Given this list of marker genes RBBP6, RABIF, HMMR, UBE3D, SRRM1, GATD3, here is a description of the gene set: from publication Stoner GD, Dombkowski AA, Reen RK, Cukovic D, Salagrama S, Wang LS, Lechner JF (PMID 18676871) studied in species Rattus norvegicus Genes down-regulated in esophagus by the carcinogen NMBA and brought back to normal by a diet with PEITC or black raspberries. Our recent study identified 2,261 dysregulated genes in the esophagi of rats that received a 1-week exposure to the carcinogen N-nitrosomethylbenzylamine (NMBA). We further reported that 1,323 of these genes were positively modulated to near-normal levels of expression in NMBA-treated animals that consumed dietary phenylethyl isothiocyanate (PEITC), a constituent of cruciferous vegetables. Herein, we report our results with companion animals that were fed a diet containing 5% freeze-dried black raspberries (BRB) instead of PEITC. We found that 462 of the 2,261 NMBA-dysregulated genes in rat esophagus were restored to near-normal levels of expression by BRB. Further, we have identified 53 NMBA-dysregulated genes that are positively modulated by both PEITC and BRB. These 53 common genes include genes involved in phase I and II metabolism, oxidative damage, and oncogenes and tumor suppressor genes that regulate apoptosis, cell cycling, and angiogenesis. Because both PEITC and BRB maintain near-normal levels of expression of these genes, their dysregulation during the early phase of NMBA-induced esophageal cancer may be especially important in the genesis of the disease. Human Gene Set: STONER_ESOPHAGEAL_CARCINOGENESIS_DN